Given this list of marker genes Tmem141, Flnc, Dab2ip, Per1, Fibcd1, S100a10, Tada2b, Sh3kbp1, Tanc2, Ndor1, Ttyh3, Nat8l, Cftr, Fbxo41, Chst15, 2010003K11Rik, Kcna1, Ppp1ca, Hmga1, Tnks1bp1 (tankyrase 1 binding protein 1), Sh3tc2, Vav2, Pld2, Bgn, Elmo1, Anpep, Ssu2, Snph (syntaphilin), Nkx2-2, Osgin1, Prkar2a, Trim30b, Dnaaf9, Pgpep1, Glis2, Adgrl1, Hapln4, Slc25a42, Zdhhc8, Crtc1, Map3k11, Adamts4, Nectin1, Dcakd, Foxd2, Rnf44 (NCBI Gene Id 105239), Itpkb, Trh, Dusp8, Adarb1, Rab4b, Camk2a (calcium/calmodulin-dependent protein kinase II alpha), Aif1l, Pcsk4, Chsy1, Mtnr1a, Nradd, Zmynd10, Mecp2, Dgkd, Syndig1l, Rerg, Arid1b, Pfn2, 4933434E20Rik, Sox12, Bcl2, Acot11, Cdc42ep1, Gab1 (growth factor receptor bound protein 2-associated protein 1), Ccdc97, Mfn2, Asxl3, Nr5a1, Clec16a, Nsl1, Tbc1d22b, Maob, Celf4 (NCBI Gene Id 81911), Plac9 (placenta specific 9), Zfp609, 4921536K21Rik, Krt73, Rph3a, Ints11, Scn2b, Rhbdd2, Sgcd (sarcoglycan, delta (dystrophin-associated glycoprotein)), Tmem132e, Ctsd, Hrh3 (NCBI Gene Id 99296), Stx1a, Luzp1, Cplx2, Aifm2 (apoptosis-inducing factor, mitochondrion-associated 2), Tns4, Dtx3, Tsc1, Trim47, Gnpda1, Unc119b, Vamp2, Phb1, Maf, Ctdsp2, Cidec, 0610030E20Rik, Nol10, Hoxc5, Plcb1, Stra6 (NCBI Gene Id 20897), Ppp1r11, Metap2, Ifitm1, Mapre1, Vipr2, Psg29, Kcna2, Psenen, Plppr2, Tmem185b, Rsph6a, Rtl5, Ly6e, Pax2, Slc6a9, Fndc5, Zc4h2, Shisal1, Zbtb44, Spock2, Carhsp1, Mark2, Arl8a, Wasf2, Eeig1 (estrogen-induced osteoclastogenesis regulator 1), Zfp593, Trabd2b, Ap1b1, Celf5 (CUGBP, Elav-like family member 5), Snai3, Tub, Gdnf, Vps41, Col18a1, Ciita, Dmbx1, Tulp3, Il22ra1, Nsg1, Ptprj, Clmn, Zfp787, Sp7, Mmp24 (matrix metallopeptidase 24), Atxn7l3, Hmga1b, Slc15a1, Tgfbrap1, Tpi1 (triosephosphate isomerase 1, NCBI Gene Id 21991), Il2rb, Klhdc3, Lhfpl4, Impdh1, Septin3, Trak1, Prpf4, Scn3a, Slc19a1, Traf3 (NCBI Gene Id 22031), Abcg4, Fgd1, Sdc3, Fcgr4, here is a description of the gene set: Genes predicted to be targets of miRBase v22 microRNA mmu_miR_6954_5p in miRDB v6.0 with MirTarget v4 prediction scores > 80 (high confidence targets). studied in species Mus musculus from publication Chen Y, Wang X (PMID 31504780) Mouse Gene Set: MIR_6954_5P